The following is a description of a gene set: Genes methylated aberrantly in HCT116 and Colo320 (colon cancer) cells. from publication Lopes EC, Valls E, Figueroa ME, Mazur A, Meng FG, Chiosis G, Laird PW, Schreiber-Agus N, Greally JM, Prokhortchouk E, Melnick A (PMID 18794111) Human Gene Set: LOPES_METHYLATED_IN_COLON_CANCER_UP Aberrant CpG methylation of tumor suppressor gene regulatory elements is associated with transcriptional silencing and contributes to malignant transformation of different tissues. It is presumed that methylated DNA sequences recruit repressor machinery to actively shutdown gene expression. The Kaiso protein is a transcriptional repressor expressed in human and murine colorectal tumors that can bind to methylated clusters of CpG dinucleotides. We show here that Kaiso represses methylated tumor suppressor genes and can bind in a methylation-dependent manner to the CDKN2A in human colon cancer cell lines. The contribution of Kaiso to epigenetic silencing was underlined by the fact that Kaiso depletion induced tumor suppressor gene expression without affecting DNA methylation levels. As a consequence, colon cancer cells became susceptible to cell cycle arrest and cell death mediated by chemotherapy. The data suggest that Kaiso is a methylation-dependent opportunistic oncogene that silences tumor suppressor genes when they become hypermethylated. Because Kaiso inactivation sensitized colon cancer cell lines to chemotherapy, it is possible that therapeutic targeting of Kaiso could improve the efficacy of current treatment regimens. studied in species Homo sapiens, and this is the list of marker genes: IFNG, TNFRSF10C, GDNF, ESR2, ESR1, TMEFF2, TWIST1, GAD1, MT1A, RARRES1, MYOD1, DLEC1, SFRP1, CCND2, SOCS1, HIC1, APBA2, APBA1, PENK, PYCARD, NKX2-1, ITGA4, MT1G (NCBI Gene Id 84785), OPCML, MGMT, SCGB3A1, CDKN2A, RARB